Given this list of marker genes Actl9, Cylc1, Ccin, Cypt1, Wbp2nl, Capzb, here is a description of the gene set: A condensed cytoplasmic structure that covers the nucleus of mammalian spermatozoa except for a narrow zone around the insertion of the tail. It shows two distinct regions, a subacrosomal layer and, continuing caudally beyond the acrosomic system, the postacrosomal sheath. The perinuclear theca has been considered a cytoskeletal scaffold responsible for maintaining the overall architecture of the mature sperm head; however, recent studies indicate that the bulk of its constituent proteins are not traditional cytoskeletal proteins but rather a variety of cytosolic proteins. Mouse Gene Set: GOCC_PERINUCLEAR_THECA studied in species Mus musculus